The following is a description of a gene set: Human Gene Set: GOMF_STRUCTURAL_CONSTITUENT_OF_MUSCLE studied in species Homo sapiens The action of a molecule that contributes to the structural integrity of a muscle fiber., and this is the list of marker genes: DMD, TCAP, MYL6B, PDLIM3, PLEC, CAPN3, OBSCN, SMTN, ACTN3, TPM4, MYOT, TTN, TPM2, NEB, MYBPC2, ASPH, MYH11 (myosin heavy chain 11), SORBS2, MYBPC3, MYOM2, MYBPC1, MYL11, CSRP2, MYBPH, SYNM, MYL1, KRT19, DAG1, MYL9, NEXN, MYOM1, MYL2, MYL6, TPM1, CSRP1, JPH1, ANKRD2, NEBL, MYH8 (myosin heavy chain 8), ACTN2, CSRP3, MYL5, MYL3